Given this list of marker genes LRRC20, SLC25A46, KIAA0232, TNFSF10 (NCBI Gene Id 8743), TRAPPC8, CDIN1, MED11, DHRS13 (dehydrogenase/reductase 13), ARHGAP5, SLC31A1, CFAP43, CALML6, MTOR, ZFP36L1, RAD54B, PTPN1 (protein tyrosine phosphatase non-receptor type 1), ACOT4, NUMBL, STAG1, RRN3P2 (RRN3 pseudogene 2), PABIR2, ANKLE1, ISX, CHD6, UGCG, IL18R1, BCL2A1, ZNF561-AS1, ZNF641, LINC00665, MTHFS, TIFA, MSTN, IQGAP3, CD226, SPTLC3, BMX, HYMAI (NCBI Gene Id 651977), USB1, KLF12, PDPR, STX7, SLC10A4, ZNF680, ANKRD7, CYP2U1, GPATCH4, PDZK1P1, DNM3OS, PSPH, AGO4, PTGR2, ISG20L2, FAM30A (family with sequence similarity 30 member A, NCBI Gene Id 9834), SYNRG, RALB, SSBP1, ENPP5, USP37, RPGR, SNTB1, CD47, METTL15, CRYBG1, GALT, CCT6B, BNIP3, C17orf100, TMEFF1, ZNF846, TGM2, LIPT2-AS1, PHF14, PTPRN2, MARK1, TMEM145, DYNC1LI1, ADISSP (adipose secreted signaling protein), ZMYND11, ZNRF2, RMDN2, AAGAB, DGKH, CDR1, ZNF407, SNORA37, SETD3, CDH7, FBXO7, KLHL34, NAT14, NET1, PLA1A, SPINT2 (NCBI Gene Id 10653), LEAP2, HEG1, ZNF662, CYB5B, KSR1, MINPP1, ASIC5, NR3C1, PSTPIP2, MAGEA6, DZIP3, CEP89, STAG2, MNS1, MUSTN1, PDXDC2P, TMEM198B, OR12D3, ADSL, GALNT12, NDUFS1, LINC02843, EXOC5, NECTIN3, GPR18, SMIM14, LMO2, HECTD2, METTL2B, C15orf48, ADH1A, KLC1, TNFRSF10A, CD302, CDC73, MS4A7, ETNPPL, TTK, ASAP1, AKNA, TUT1, SLC41A2, UHMK1, SNX7, RAB18 (NCBI Gene Id 22931), ABI1, ACVR1, MALT1, FBN2, PIKFYVE, PDCD6, ATP8A1, ITSN2, KCNQ5, MAPK1, ZNF551, GPRIN1, HAS2, PPM1A, LCN12 (lipocalin 12), CRYZL1, TPTE2P6, COPG2 (NCBI Gene Id 80038), IL4I1, ELMOD1, KIAA1549L, CXorf38, EBNA1BP2, LINC00887, ENOX2 (ecto-NOX disulfide-thiol exchanger 2), PIGF, CCDC144BP, ACBD6, TAF1A, POLR3G, ELP1, P2RY12, SYTL1, SPATA31G1, PCNX2, CHRNA1, FANCB, RAI14, ASB2, SYNGR2, ATAD2B, SLC30A9, KHNYN, CYP27B1, SPRYD7, TUBBP5, RGS3, SERPINB1, MARCHF5, NPTX1, RPIA, NIBAN3, UPRT, CDC37L1, NUDT19, here is a description of the gene set: Human Gene Set: GSE25502_WT_VS_KLF13_KO_THYMIC_MEMORY_LIKE_CD8_TCELL_UP Genes up-regulated in thymic memory like CD8 cells: wildtype versus KFL13 knockout. “Memory-like T cells” are a subset of thymic cells that acquire effector function through the maturation process rather than interaction with specific antigen. Disruption of genes encoding T cell signaling proteins or transcription factors have provided insights into the differentiation of such cells. We show here that in BALB/c but not C57BL/6 mice, a large portion of thymic CD4-CD8+ T cells exhibit a memory-like phenotype. In BALB/c mice, IL-4 secreted by invariant natural killer T (iNKT) cells is both essential and sufficient for the generation of memory-like T cells. In C57BL/6 mice, iNKT cells are less abundant, producing IL-4 that is insufficient to induce thymic memory-like CD8+ T cells. BALB/c mice deficient in the transcription factor Kruppel-like factor (KLF) 13 have comparable numbers of iNKT cells to C57BL/6 mice and extremely low levels of thymic memory-like CD8+ T cells. This work documents the dramatic impact of a small number of KLF13-dependent iNKT cells. from publication Lai D, Zhu J, Wang T, Hu-Li J, Terabe M, Berzofsky JA, Clayberger C, Krensky AM (PMID 21482696) studied in species Homo sapiens